The following is a description of a gene set: Mouse Gene Set: GOBP_INTERLEUKIN_1_ALPHA_PRODUCTION species: Mus musculus The appearance of interleukin-1 alpha due to biosynthesis or secretion following a cellular stimulus, resulting in an increase in its intracellular or extracellular levels., and this is the list of marker genes: Il1r2, Spag11a, Nlrp10, Panx1 (pannexin 1), Cx3cl1, Isl1, Il16, Ptger4, Ccl20, Nlrp1b, P2rx7, S100a13, Casp1